The following is a description of a gene set: Human Gene Set: GOMF_CATALYTIC_ACTIVITY_ACTING_ON_A_NUCLEIC_ACID Catalytic activity that acts to modify a nucleic acid. studied in species Homo sapiens, and this is the list of marker genes: FTSJ3, POLR2E, HFM1, DHX30, DDX18, POLB, PMS2P6, FARS2, WARS1, REV1, DDX56, N4BP2, CRY2, WRNIP1, EXOSC3, PMS2P3, POLR3G, ZC3H12B, PCIF1, RAD54B, RAD54L, ATAD5, DDX51, POLR2H, METTL2A, PUS1, TREX2, HELZ, EXO1, RIGI, WRN, POLR2B, RARS1, TOP2B, MCM9, PTRH2, DYNLL1, DDX5, EXD2, B3GNTL1, PAN3, MCM6, DDX47, GEN1, TRMT2B, ALKBH3, NARS1, HMCES, UVSSA, DCLRE1C, ERCC2, TYW3, RNASEH1, MARS1, THG1L, RAD54L2, FBH1, SKIC2, ERI1, MCM5, EXOSC1, DDX49, DNMT1, RECQL5, DHX38, CHD7, TRMT5, PUS7, WARS2, EXOSC10, PNLDC1, SLFN14, POLR3F, PIF1, RFC4, RNASE2, NME1 (NCBI Gene Id 7794), TOE1, RNASEL, XRN2, LARS2, TET2, DARS1, TRMT2A, DDX41, MEPCE, SMARCAL1, TRMT61A, GGT5, BTAF1, DDX39A (NCBI Gene Id 95781), BRIP1, RNASEK, RNASE9, EARS2, TSNAX, POP5, TGS1, TRMU, RPP40, MYG1, TRMT10B, PRORP, APEX2 (NCBI Gene Id 27301), DDX43, TYW1B (NCBI Gene Id 442576), DHX58, TRMT11, POLR3A, MSH3, NOCT (nocturnin), N6AMT1, RAD51B, POLR3B, ZGRF1, SARS2, TATDN1, HENMT1, ERN2, PPP1R8, DDX24, DBR1, SUPV3L1, PUSL1, CDK7, RNASE6, DDX23, SNRNP200, DHX36, RNASET2, SEPSECS (NCBI Gene Id 51091), THUMPD2, AEN, FXR1, FMR1, TRMT12, RNASE7, RNASE3, CHD5, DDX21, RPP30, PMS2P5, PARS2, RAD17 (RAD17 checkpoint clamp loader component), ERI3, POLM, TRMT9B, POP1, DSCC1, CDKAL1, QTRT2, PUS10, MARS2, POLR3H, DDX11, RAD51, CARS1, DALRD3, DNTT, POLQ, CHD8, POLR1C, NIPBL, RCL1, ZC3H12D, IGHMBP2, TUT1, QTRT1, OGG1, DMC1, MARF1, TOP1, MAU2, DFFB, CRY1, TRMO, MTFMT, MPG, DDX60L, XRN1, DHX15, WAPL, DTD1, DNASE1L1, FTO, INO80, ALKBH2, MUTYH, DDX6, TTF2, POLR2K, N4BP1, CHD2, METTL15, FARSA, CHD9, RBBP8, PINX1, LIG1, MRM1, RNGTT, POLG2, EIF4A3, CMTR1, SLFN13, DDX52 (DExD-box helicase 52), RNASE12, DHX9, METTL8, EXOG, ZCCHC4, HELQ, SETMAR, TDG, TRMT13, MYD88, AARSD1, POLE3, RPP21, SLU7, THUMPD3, MED20, DFFA, DHX34, PAN2 (NCBI Gene Id 9924), FBLL1, SLX1B, MCM8, ERCC3, PIWIL2, ERCC5, APEX1, NSUN5, CNOT6L, DHX8, ELAC1, LACTB2, CPSF3, AARS2, PMS2, DDX55, DDX11L8, TUT4, POLR1H, SPOUT1, BRAT1, ISG20, TFB2M, PRORSD1P, SETX, LRRC47, TEFM, MGME1, ANG, NOB1, SARS1, RTCB, PCNA, DHX57 (DExH-box helicase 57), MRM3, DICER1, DDX3Y, MLH1, TOP1MT, FEN1, HARS2, GATB, SRCAP, BCDIN3D, TARBP1, C1QBP, DIS3L, VARS2, IARS1, DTWD2 (NCBI Gene Id 285605), POLR1D, AGO2, ALKBH1, ISG20L2, DDX54 (NCBI Gene Id 79039), REXO2, TERT, ZC3H12C, EPRS1, POLD4, NUDT12, DHX35, LARS1, PNPT1, CHTF18, TERF2, DDX60, RECQL4, NT5C3A, SMARCA2, TARS1, TMBIM6, LIG3, POLR2L, PUS3, NSUN3, CHRAC1, DDX12P, EME1, TFB1M (NCBI Gene Id 51106), PGBD5, METTL15P1, GTDC1, RFC5, NUDT16, TRUB2, DKC1, TET1, EIF4A2, TSEN34, NEIL3, ENDOV, ERCC6, RPP14, NTHL1, CECR2, UPF1, HLTF, CHTF8, POP7, RPP38, MCM2, CNOT1, TEP1, TOP3A, POLG, BUD23, RAG1, XRCC5, DTWD1, NSUN5P1, FDXACB1, TUT7, RPS3, NOP2, POLR2A (RNA polymerase II subunit A), PIWIL4, DHX32, AGO1 (argonaute RISC component 1), TRMT1L, RPUSD4, ETF1, EXOSC8, FANCM, DUS1L, BLM, TOP2A, NSUN5P2, PRIM2, EXO5, MTO1, RFC2, CHD1, MTREX, HMGA2, RPPH1, RARS2, DDX28, DDX17, HELZ2, RIDA, MRPL44, RFC3, ERI2, DDX3X, CNOT8, PTRH1, METTL2B, IFIH1, GARS1, EIF4H, NARS2 (asparaginyl-tRNA synthetase 2, mitochondrial), TARS2, JMJD6, POLK, RSF1, TDP1, SND1, MCRS1, DHX16 (NCBI Gene Id 8449), MRPL58, FARSB, XRCC3, RLIG1, YARS1, DDX50, POLR3C, DARS2, POLN, MSH2, DIMT1, MAP1S, QARS1 (glutaminyl-tRNA synthetase 1), PARN, METTL6, MED21, POLD3, TARS3, DDX1, METTL1, EXOSC4, RNASEH2A, DDX27, TREX1, RNASE1, KARS1, APLF, TSEN2, DHX37, MRE11, XRCC2, ABCE1, MCM7 (NCBI Gene Id 4176), PLD3, DIS3L2, DTD2, MRM2, TMT1A, RNASE10 (NCBI Gene Id 493622), YARS2, GATC, ASCC3, PDE12, BPTF, DUS4L, DCPS, RTEL1, IARS2, RNASE8, POLR2J, POLD1, DHX33, DUS3L, APTX, EXOSC5, MSH4, ERCC6L, POLH, DDX19B, RNASE13, LCMT2, DROSHA, TWNK, TRIT1, TRMT61B (NCBI Gene Id 55006), TYW5, BIVM, CNOT2, RECQL, TRPT1, XRCC1, RUVBL2, EP400, TYW1, ENDOU, PSTK, ELAC2, RNASE11, LIG4, CMTR2 (NCBI Gene Id 55783), NSUN4, ERN1, RAD51D (NCBI Gene Id 5892), POLR2F, DDX46, POLR1A, DIS3, POLR3K, MGMT, TRDMT1, TDRD12, YTHDC2, NUDT16L1, THAP9, FAN1, POLE2 (NCBI Gene Id 5427), RAD51C, EXOSC2, NEIL2, HELB, TRMT44, ENDOG, SMUG1, CHD4, EXOSC7, NYNRIN, TDRD9, SLFN11, METTL16, ANKLE1, ERCC4, DNASE1, EMG1, AZGP1, SHPRH, SLX1A, POLR2C, SPO11, TRNT1, DDX10, SAMHD1 (NCBI Gene Id 25939), CNOT7, VARS1, RNH1, PMS1, MCM4, SMARCA4, G3BP1, TEN1, YBEY, TERF1, POLR2J2, CARS2, ERCC6L2 (NCBI Gene Id 56959), DDX53, NEIL1 (NCBI Gene Id 79661), EXOSC6, PIWIL1, MUS81, DNA2, MSH6, ZRANB3, ALKBH5, PRIM1, RAD9A, RTCA, TDP2, MSH5, RPP25, DCP2, SMARCAD1, MOV10L1, TOP3B, POLI, MYO18A, CWF19L1, POLRMT (NCBI Gene Id 5442), DHX29, METTL3, REV3L, DDX59, USB1, NAV2 (neuron navigator 2), DHX40, NSUN6, ALKBH8, XRCC6, METTL14, TRMT1, SLFN12, TRMT10A, TRMT10C, ANKZF1, PTRHD1, AGO3, POP4, AQR, DDX42, NSUN2, CHD6, INTS11, ZC3H12A, TERC, DDX31, TRUB1, POLL, AGO4, POLR1B, TET3, RNASE4, DCLRE1B, DDX19A, RBBP4, PLD4, RFC1, DCLRE1A (NCBI Gene Id 9937), DDX20, MBLAC1, POLE4, CDK5RAP1, RNMT, MBD4, EXOSC9, GTPBP3 (NCBI Gene Id 84705), METTL4, DXO, ATRX, CNOT6, POLR2I, EME2, MCM3, HELLS, ACD, GGT1, RAD50, PRIMPOL, CRCP, POT1, EIF4A1, DDX25, FBL, PMS2P1, DQX1, MLH3, ZNFX1, HMGA1, METTL25B, PLD6, SMARCA1, KHNYN, ERCC1, DNMT3A, UNG, DNASE2, MOV10, MEIOB, DDX4, AARS1, POLE, DNMT3B, DDX39B, POLA1, TSR3, EIF4B, SMG6, POLR2J3, CHD1L, ALKBH4, QRSL1, RAD1, RUVBL1, FTSJ1, DNASE2B (deoxyribonuclease 2 beta), METTL5, ASTE1, TP53, DUS2, DNASE1L2, SMARCA5, PIWIL3 (NCBI Gene Id 440822), DNASE1L3, PTGES3, HARS1, CHD3, UBE3D